The following is a description of a gene set: Human Gene Set: GSE22432_MULTIPOTENT_PROGENITOR_VS_PDC_DN from publication Felker P, Seré K, Lin Q, Becker C, Hristov M, Hieronymus T, Zenke M (PMID 20881193) species: Homo sapiens Genes down-regulated in dendritic cells: amplified common progenitors versus plasmacytoid. Dendritic cells (DCs) in lymphoid tissue comprise conventional DCs (cDCs) and plasmacytoid DCs (pDCs) that develop from common DC progenitors (CDPs). CDPs are Flt3+c-kitintM-CSFR+ and reside in bone marrow. Here we describe a two-step culture system that recapitulates DC development from c-kithiFlt3-/lo multipotent progenitors (MPPs) into CDPs and further into cDC and pDC subsets. MPPs and CDPs are amplified in vitro with Flt3 ligand, stem cell factor, hyper-IL-6 and insulin- like growth factor-1. The four-factor cocktail readily induces self-renewal of MPPs and their progression into CDPs and has no self-renewal activity on CDPs. The amplified CDPs respond to all known DC poietins and generate all lymphoid tissue DCs in vivo and in vitro. Additionally, in vitro CDPs recapitulate the cell surface marker and gene expression profile of in vivo CDPs and possess a DC-primed transcription profile. Transforming growth factor-β1 (TGF-β1) impacts on CDPs and directs their differentiation towards cDCs. Genome-wide gene expression profiling of TGF-β1-induced genes identified transcription factors, such as interferon regulatory factor-4 (IRF-4) and RelB, that are implicated as instructive factors for cDC subset specification. TGF-β1 also induced the transcription factor inhibitor of differentiation/DNA binding 2 (Id2) that suppresses pDC development. Thus, TGF-β1 directs CDP differentiation into cDC by inducing both cDC instructive factors and pDC inhibitory factors., and this is the list of marker genes: NUP85, FAM120A, TUBGCP3, U2AF1, PDLIM2, PAFAH2, AUNIP, ARHGAP9, NUP107, CLPTM1L, MRPS35, PRKAB2, EIF2B3, GAS8, ANKRD26, NFYA, DGKZ, SNRPA1, JKAMP, ATP13A3, GCSH, SRSF9, BTBD19, ABHD11 (NCBI Gene Id 83451), DDX31, TIMM13, STRAP, MANF, LIPT2, JAKMIP3, PGM2L1, MTPAP, LUC7L, NDUFAB1, GOLGA7, DVL2, ARPC5L, PITPNB (phosphatidylinositol transfer protein beta), NELFB, G2E3, MRPL2 (mitochondrial ribosomal protein L2), DTYMK, CEBPZ, CHTOP, RAB14, NAA10, CD200R1L, ATP5F1A, MYCBP, ARFGAP2, GLE1, TIMM10, UCHL5, HS2ST1, ADSL, PLEKHG3, TOM1, GALNT3 (NCBI Gene Id 2591), TRAPPC11, DAGLB, TTLL4, ATE1 (arginyltransferase 1), PPIG, SENP5, CEP44, PPCS, JAGN1, ACAT1, CACNG8, RHOBTB1, SCOC, MDH2 (malate dehydrogenase 2), XKR6 (NCBI Gene Id 83654), NUP58, PPP1R21, SMCO4, TIMM23, SVIL, SIX4, ZCCHC17, TDP1, SUV39H2, SSNA1, NKRF, TATDN2, NAA38, TARS1, TRIM28, ZNF664, MFSD3, SNHG17, GNL3L, EXOSC1, BUD23, TRNAU1AP, SH3PXD2B, RGS11, RPL22, SLC35A4, SNRPB2, UST, UTP4, CHST11, IARS2, ZNF560, BRIP1, PSMD1 (proteasome 26S subunit, non-ATPase 1), SNX8, YEATS2, CGNL1 (cingulin like 1), BUB3, DRG2, HLCS, FAM91A1, EIF2B1, ACOX1 (NCBI Gene Id 8308), DCUN1D2, NT5DC1, KCNE3, GARS1, TRIM3, OTULIN (NCBI Gene Id 90268), CLNS1A, PRKAG2, PIGT, DEPTOR, POLE, PARP16, ZDHHC17, PPP5C, PITRM1, CEP152, RABL3 (RAB, member of RAS oncogene family like 3), NOP56, PPM1G, IMP3, NCF1, SLF1, RCC1L, MEMO1, RASAL2 (NCBI Gene Id 9462), SPTSSA, CAD, MMUT, PSMA7, BTD, SMIM15, RAD51AP1, GTF2A2, HYPK, CEP55, RPAP2, ABHD4, RAD17, PLPP5, STK17B, ALDH18A1, PARP2, ZSWIM7, RCC2, LAIR1, DFFB, RAD54L, PDE4DIP, SLC25A13, SLC20A1, RNF150, ORC6, FOSL2 (FOS like 2, AP-1 transcription factor subunit), SLC1A5, UFL1, RRP9, TMEM199, PHB2, PHTF2, SUPV3L1, UBE2T, CCNA2, ZNHIT3, TAFAZZIN, FARSA, DCAF1, HIBCH, PMS2, ZNF764, VAPB, MRM3, MRPL52, MEPCE, PSMD2, SAMM50, IL1RL2, SNAPC3, HCCS, DPY30, BAG4, SMIM30, SRP54, EIF3I, SLC25A3